Given this list of marker genes Phldb1, Ephb2, Slc7a1, Rnf20, Pcdha1, Pcdhb16, Alyreffm14, Zfp142, Pcdhac1, Tcf12, Agap1, Mier1, Alyreffm17, Arhgef9, Alyreffm16, Pcdha4, Tnrc6b, Galnt17, Slc4a8, Slc24a2, Kif1b, Rapgef3, Cyyr1, Adam12, Zfp385a, Rad54l2 (NCBI Gene Id 81000), Sez6l2, Pcdh10, Mup3, Magi2, Tpst2, Pcdha11, Krtap5-5 (NCBI Gene Id 114666), Mpp2, Zxdb, Zfp157, Rhot1, Gpr21, Dhx40, Trem3, Dcaf17, Csnk2a1, Pcna, Pcdha3, Fktn, Syn1, Eif4h, Phlpp2, Hook3, Plxna4, Gpr156, Slc41a1, Rock2, Dgkk, Plekhh1, Gsk3b (glycogen synthase kinase 3 beta), Heyl, Usp3, G6pc1, Coro2b, Trappc2, Klk5, Cldn23, Dnase1l3, Pcdha12, Notch2, Zmpste24, Hipk1, Ppp6r1, Dlg2, Csf3, Ano5, Zmym3, Atp1a3, Rora, Pcdha6, Eps8l1, Xylt2, Klhl34, Slc16a2, Adgrb1, Pcdha10, Csmd2, Fchsd2, Ikbkg, Cgn, Smg7, Igf1, Pcdha2, Zup1, Pcdha5, Apba1, Ppp2r1b, Rab27b, Ago1, Rae1, Pip5k1c, Anxa2, Tmed5, Phactr2, Fgf14, Six3 (sine oculis-related homeobox 3), Cnot9, Map4k4, Arl4a, Slc9a1 (NCBI Gene Id 20544), Grb2, Dcaf8l, Hsf5, Flot2, Svs3b, Srgap2, Tspan11, Ssu72, Idua, Taok3, Cdyl2, Grhl2, Nucb2, Rheb, Ankfy1, Pcdha9, Nr1d1, Plekhg4, Rab3d, Rit2, Otof, Adam22, Arl8b, Celf2, Fam163b, Creb3l2, Dusp15, Sox13, Thra, Cpeb3, Apobec1, Rere, Tead1, Robo2, Sgms1, Glod5, Pcdhac2, Rbfox2, Pcdha7, Alyreffm11, Dars1, Enc1, Hic2, Car10, Cdc42, Syndig1l, Tmco5b, Crtac1, Brpf3, Cbfa2t3 (CBFA2/RUNX1 translocation partner 3), Ark2c, Ralgapb, Nol6, Coro1c (coronin, actin binding protein 1C), Pak2, Trpc4ap, Amotl1, Ocln, Bcat1, Dynll2, Ctla4, Kcne1, Wnt7a, Tecr, Rprd2, Alyreffm10, Plekhb1, Ntrk2, Tspan18, Zscan20, Alyreffm15, Elp4, Carmil1, St6galnac3, Jph4, Igf1r, Synm, Zfp938, Tox3, Ube2d2b (ubiquitin-conjugating enzyme E2D 2B), 1700019A02Rik, 4921536K21Rik, Gdf5, Mat2a, Slc4a5, Fbxl17, Cntd1, Ccdc174, Pth, Adam2, Fam124a, Clstn1, Grem2, Alyreffm13, Cfl2, here is a description of the gene set: studied in species Mus musculus Mouse Gene Set: MIR_185_5P Genes predicted to be targets of miRBase v22 microRNA mmu_miR_185_5p in miRDB v6.0 with MirTarget v4 prediction scores > 80 (high confidence targets). from publication Chen Y, Wang X (PMID 31504780)